Given this list of marker genes Hoxa5, Brca2, Ccnd1, Zfas1, Agap2, Kdm5b, Rreb1, Phb2, Deaf1, Zfp703, Pygo2, Gata3, Bax, Gpx1, Rtn4, Cdkn2a, Etv4, Iqgap3, Mst1, Robo1, here is a description of the gene set: Mouse Gene Set: GOBP_REGULATION_OF_MAMMARY_GLAND_EPITHELIAL_CELL_PROLIFERATION Any process that modulates the frequency, rate or extent of mammary gland epithelial cell proliferation. species: Mus musculus